The following is a description of a gene set: An intracellular protein kinase cascade containing at least a MAP kinase (MAPK). It starts with the activation of a MAP3K, and the consecutive activation of a MPK2K and a MAPK. The cascade can also contain an additional tier: the upstream MAP4K. The kinases in each tier phosphorylate and activate the kinase in the downstream tier to transmit a signal within a cell. studied in species Mus musculus Mouse Gene Set: GOBP_MAPK_CASCADE, and this is the list of marker genes: Hyal2, Stk4, Gadd45b, Pabpn1, Adra2b, Dusp8, Smad4, Avpi1, Prok1, Casr, Gpr183, Mapk8, Zfp36, Lilra5, Insr, Nmnat1, Cckbr, Aida, Ccl19-ps5, Fgd4, Kl, Fam3c, Bcl10, Dsc2, Daxx, Lpar3, Dusp16, Fgfr4, Mapk14, Ntrk2 (NCBI Gene Id 77471), Cxcl12, Raf1, Foxo1, Pde6g, Fgf17, Npsr1, Fgfr2, Dusp13b, Pdcd4, Cavin3, Adrb2 (NCBI Gene Id 269028), Il3, Il6ra, Igf2, Igf1, Pdgfa, Ccdc88c, Fgf22, Nrbp1, Adrb1, Fgf10, Mbip, Traf6, F2rl1, Eif2ak2, Lepr, Naip1, Pdgfc, Jak2, Nrg1, Tgfb2, Drd2, Slc30a10, Tab1, Syngap1, Map2k3, Dnaja1, Cd36, Peli2, Nrk, Dvl2, Lax1, Prdm11 (NCBI Gene Id 278932), Sirpa, Fgf23, Chrna7, Nenf, Nrxn1, Spry2, Cd40, Lmo3, Myh9, Nptn, Fshr, Tpbg, Pla2g2a, Pik3cg, Map2k5, Fgf21, Gsdme, Dusp19, Cd2ap, Pbp2, Fzd8, Dok1, Pdgfra, Tnik, Bcar3, Egf (NCBI Gene Id 99717), Ash1l, Ext1, Clcf1, Ccl19-ps3, Stk25, Dusp7, Ptprj, Tlr2, Ccr7, Pin1, Bank1, Mapk12, Notch1, Ghrl, Camk2d, Phb2, Tlr7, Mdfic2, Mink1, Alox12b, Sfrp2, Rb1cc1, Map3k12, Robo1, Jun, Oprm1, Taok2, Atf7, Tgfb3, Iqgap1, Tbx1, Fgfbp3, Dab2, Crk, Nampt, Mylk2, Ccl19-ps4 (C-C motif chemokine ligand 19, pseudogene 4, NCBI Gene Id 100040035), Lrrk2, Eif3a, Nqo2, Map4k1, Cripto, Tirap, Il11 (interleukin 11), Psen1, Clec7a, Ern1, Trp73, Gpnmb, Hacd3, Mfhas1, Madd, Timp2, Pafah1b1, Adra1b, Nelfe, Sash1, Dact1, Syk, Uchl1, Tnfrsf11a, Cspg4, Fem1a, Arrb1 (arrestin, beta 1), Sema6a, Ddr2, Sorbs3, Xdh, Bnip2, Ulk4, Gfral, Asb3, Smpd1, Map2k6 (NCBI Gene Id 26399), Nek10, Dmd, Apela, Gcnt2, Irak4, Esr2, Erbb2, Hras, Tpbpa, Akt1, Avpr1b, Gadd45a, Tlr13, Fam83d, Adam8 (a disintegrin and metallopeptidase domain 8), Rock1, Tnf, Pak5 (NCBI Gene Id 73084), Ccl11, Avp, P2ry6, Lif, Synj2bp, Wnt5a, Naip5, Brap, Mecom (MDS1 and EVI1 complex locus), Ltbr, Stub1, Cd81, Cav3, Fgf8, Rgs2, Sphk1, Ccr3, Trim30a, Tff2, Kiss1r, Necab2, Igfbp4, Ins2, Mir504, Epha2, Edn1, Efna1, Fbxw7, Calcr, Pten, Naip6, Ffar4, Map2k2, Fgb (fibrinogen beta chain), Taok1, Crkl (v-crk avian sarcoma virus CT10 oncogene homolog-like), Map3k15, Pramel7, Mapk8ip2, Gps2, Sfrp4, Pak2, Mos, Prdm15, Dusp10, Cyld, P2rx7, C1ql4 (complement component 1, q subcomponent-like 4), Pea15b-ps, Pbk, Edar, Adra2a, C5ar1 (complement component 5a receptor 1), Lyn, Dusp9, Cysltr2, Csf1r, Ccl21e, Rapgef2 (Rap guanine nucleotide exchange factor (GEF) 2), Zfp622, Drd4, Rgs14, Lemd2, Sh3rf2, Grem1, Dnajc27, Fgf14, Lmnb1 (NCBI Gene Id 16906), Ins1, Nppa, Pik3r6, Lpar1, Gdf6 (growth differentiation factor 6), Ankrd6, Flcn, Cx3cl1, Klhl31, Wnk4, Nkd1, Mapkapk2, Nppb, Lep, Chrna10, Tbc1d10c, Spi1, Ccl21d, Kcnj8, Plcb1, Prkce, Fpr2, Ccnq, Cd300a, Plcg2, Tnfsf11, Gpr37, Ccl3, Gba1, Hdac3, Dag1, Pak4, Gstp2, Prkcd, Scimp, Gpr37l1, Mt3, Fpr-rs4, Pik3cb, Ncor1, Blvra, Ephb2 (Eph receptor B2), Paqr3, Sod1, Psmd10, Ephb1, Epha8, Pp2d1, Trib1, Gsn (gelsolin), Rap1gds1, Eda2r, Marveld3, Slamf1, Adam9 (NCBI Gene Id 11502), Laptm5, Cd84, Birc7, Fgf9 (NCBI Gene Id 252883), Inpp5k, Fgf13, Map2k1, Ndrg2, Ptprr, Esr1, Tgfbr3 (NCBI Gene Id 73753), Sos1, Il34, Zc3h12a, Styx, Rap2a, Kiss1 (KiSS-1 metastasis-suppressor), Cdon, Map3k20, Grap2, Wnt16, Klb (klotho beta), Phlpp1, Ccl21a, Tenm1, Pdgfb, Ccr5, Vrk3, Havcr2, Pde8a, Fgfr3, Ppia, Map3k19, Unc5cl, Prkca, Oprk1, Cracr2a, Cnksr3, Kcnn4, Abca7, Bmp2, Bmpr1b, Grin2b, Il6, Nod1, Lamtor1, Fpr-rs6, Ripk1, Cbs, Stk38, Map1lc3a, Lilrb4a, Rps3, Cd44, Pak3 (NCBI Gene Id 18481), Fgg, Dkk1, Adipoq, Ace2, Wnk2, Frs2, Dab2ip, C3, Hgf, Kars1, Trim30b, Magi3, Atp6ap2, Glipr2, Rhbdd3 (rhomboid domain containing 3), Dok2, Fn1, Adra1d, Naip2, Inppl1, F2r, Pak1, Akap12, Ager, Xbp1, Ece1, Mapk4, Epha4, Ptpn6, Itgb3, Araf, Map3k13, Ercc6, Map3k3, Dusp15, Abcc9, Fgf3, Ptpn1, Adam17, Adcyap1, Irak3, Tpd52l1, Zeb2, Asb15, Nf2, Ripk2 (receptor (TNFRSF)-interacting serine-threonine kinase 2), Icam1, Prkd2, Adrb3, Map3k11, Hmgb1, Map3k8, Myd88, Mef2a, Mdfi, Gstp1, Map4k5, Rnf13, Ntrk3, Rps6ka6, Per1, Stradb, Nlk, Angpt1, Zdhhc17, Zmynd11 (zinc finger, MYND domain containing 11), Dusp3, Spred2, Wnt7a, Edn3, Stk3, Met, Mydgf, Grap, Ptpn11, Map3k1, Atf3, Dlg1, C1qtnf3, Cblc, Fbln1, Fktn, Chrna9, Mapk15, Pla2g5, Ceacam2, Cdc42se1, Ngfr, Wwc1, Mapk13, Prdx1, Cops5, Grb2, Pou4f2, Atp6v0c, Bmper, Cryba1, Rac1 (NCBI Gene Id 52352), Igfbp6, Fcer1a, Sh3rf1 (SH3 domain containing ring finger 1), Jcad, Alkal1, Spry1, Mapk9, Map3k10, Erbb4, Chi3l1, Dusp29, Lamtor3, Rell1, Ndrg4, Ptpn22, Fgf20, Mapk8ip1, Fzd5, Fgd2, Trf, Ccl19-ps1, Spry4, Cav1, Fpr-rs3, Hand2, Mif, Pik3ap1, Adora2a, Arrb2, Id1, Dynlt1b, Fgf5, Trim12c, Dbndd2, Dok4, Scg2, Map4k4, Cdh2, Rit2, Dok5, Cflar, Apip, Itch, Bmpr2, Klhdc10, L1cam, Nherf1, Htr2b, Klf4, Fgf16, Wnt4, Gper1 (NCBI Gene Id 76854), Nox4, Wnt7b, Fgf7, Oxtr, Irak1, Crhr2 (NCBI Gene Id 12922), Ren1, Trim30c, Bmyc, Xiap, Spred1, Qars1, Ntsr2, Errfi1, Dusp4, Erp29 (endoplasmic reticulum protein 29), Itpkb, Epor, Pak6, Map3k21, Npy5r, Cdk10, Itgav, Tgfa, Arl6ip5, Pde5a, Tlr9, Pkhd1, Shoc2, Mst1r, Ptk2, Gadd45g, Tnfaip8l3, Lpar2, Map4k2, Tnxb, Epo, Maged1, Epgn, Gstp3, Arhgap8, Ror2, Cav2, Pxn, Nrp1, Atp1a3, Zfp36l2, Htr2c, Itgb1bp1, Tmem106a, Shank3, Hipk2, Acta2, Men1, Fgf2, Mapk6, Tnip1, Ccr1, Spred3, Spag9, Dsg3, Notch2, Nlrp12, Hipk3 (homeodomain interacting protein kinase 3), Pik3r2, Cdc42ep5, Lilrb4b, Tiam1, Mapkbp1, Thpo, Nup62, Inhba, Thbs1, Ccl21f, Tlr6, Fgf18, Gpr39, Ccl21b, Ywhaz, Plvap, Rras, Inava, Agt, Prkn (parkin RBR E3 ubiquitin protein ligase), Ndst1, App, Trim5, Dusp2, Nbr1, Map3k6, Rap1a, Braf, Cxcl17, Npnt, Rnf149, Pebp1, Rasgrp1, Egfr, Ntrk1, Pik3r5, Ptprc, Dusp6, Phb1, Ezh2, Dusp26, Erbb3, Csk, Vangl2, Arhgef5, Fermt2, Ighm, Btn2a2, Ntf3, Gpbar1, Npr2, Becn1, Sirt3, Hrh4, Abl1, Nphs1, Ksr2, Ppef2, Mapk11, Gcg, Pdgfrb, Cxcr4, Sox9, Lrp1, Dusp22, Ramp3, Fcgr2b, Htr2a, Psca, Map3k4, Serpinf2, Akap13, Smad1, Map3k14 (mitogen-activated protein kinase kinase kinase 14), Fzd7, Bmp4, Cdk5rap3, Il1a, Cartpt, C1qtnf2, Map3k2, Smad3, Sla, Pdcd10, Drd5, Ccl19-ps6, Marco, Ros1, Ilk, Lamtor2, Pdgfd, Il1b, Dennd2b, Npy (NCBI Gene Id 68398), Adra1a, Pde8b, Fas, Ngf, Fgfr1, Styx-ps, Styxl2, Grm1, Ccr2, Nr2c2, Mapk7, Prmt1, Gpr55, C1qtnf1, Tlr4, Cntf, Cdc42, Dixdc1, Ctnnb1, Grb10, Mapk10, Or2at4, Ret, Lbh, Kit, Sbno1, Mturn, Trim12a, Alox15, Ajuba, S2bpcox16, Cib1, Mapk3, Ksr1, Flt4, Hmgcr, Map3k7 (NCBI Gene Id 93774), Ptpn2, Fgf15, Lat, Pparg, Psap, Tek, Ywhae, Grm4, Prkcz, Myc, Garem1, P2ry1, Myoc, Trpv4, Ranbp9, Drd1, Fgf1, Card9, Nfkb1, Zfp36l1, Cryab, Traf7, Osm, Abl2 (NCBI Gene Id 98214), Adora1, Trem2, Sh2b3, Cd4, Adra2c, Fgf6, Taok3, Gdf15, Dvl3, Pin1rt1, Pja2 (NCBI Gene Id 224938), Gab1, Dhx33, Trim30d, Ankrd26, E130311K13Rik, Ryk, Igfbp3, Ackr3, Ar, Dstyk, Map2k4, Hsf1, Grik2, Iqgap3, Rassf2, Dcc, Ccn1, Cd24a, Ppm1l, Traf4, Gstp-ps (glutathione S-transferase, pi, pseudogene), Muc20, Dusp1, Vegfa, Pde6h, Rap1b, Rell2, Mid1, Sstr4, Hcrtr1, Zfp110, Traf2, Igf1r, Pea15a, Itga1 (integrin alpha 1), Mapk1 (mitogen-activated protein kinase 1), Nod2, Ccn2, Sox2, Sfrp1, Stk40, Foxm1, Rapgef1, Map2k7, Npffr2, Sema7a, Tnfrsf19, Axin1, Tgfb1 (NCBI Gene Id 21803), Fzd10, Ptk2b, Cd27, Prdx2 (peroxiredoxin 2, NCBI Gene Id 98489), Mapk8ip3, Map3k5, Sema4c (sema domain, immunoglobulin domain (Ig), transmembrane domain (TM) and short cytoplasmic domain, (semaphorin) 4C), Nodal, Fbxo21, Alkal2, Tlr3, Epha7, Mef2c, Cntnap2, Kdr, Shc1, Vegfb, Sfrp5, Ern2, Vrk2, Atf2, Nlrp6, Ccl19, Wdr54, Mbp, Fzd4, Bmpr1a, Map4k3, Flt1 (FMS-like tyrosine kinase 1), Emilin1, Prxl2c, Ptger4, Grm5, Sbk2, Fgf4, Map3k9, Rock2, Dusp5, Apc, Rnf41, Cd74, Nf1, Ezr, Fga, Stk39, Ccr1l1, Apoe, Gpr101, Ednra, Gas6, Fpr-rs7, Ctsh (cathepsin H), Prmt5, Mdfic, Sh3rf3, Nox1, Hesx1, Fgf12, Iapp, Pycard, Kitl, Src (NCBI Gene Id 99351), Gnai2, Ceacam1